Given this list of marker genes WBP2, ALDH3A2, MINDY2, SLCO3A1, AKT3 (AKT serine/threonine kinase 3), KDM5B, SYNPO, PTPRE, RIPK3, NIBAN1, DPY19L3, KMT5B, TAX1BP1, UVRAG, SUPT20H (SPT20 homolog, SAGA complex component), MOB1A, CMC1 (NCBI Gene Id 152100), PHF21A, GNPDA2, ZXDC, PDZD4, VRK3 (VRK serine/threonine kinase 3), PRKACB, DDIT4, PPP2R5E, TBRG1, MADD, CCDC18, DYNLRB1 (dynein light chain roadblock-type 1), CWC15, HMG20A, SERINC1 (serine incorporator 1), SIDT2, PTGER2, SMAP2, BPTF, BMAL1, BTD, SYNRG, RNF138, ERLEC1, PTPN11 (protein tyrosine phosphatase non-receptor type 11), TNIK, INSIG2, TSPAN13, SORL1, GOLM1, DOP1B, FAM120B, FBXO4, VPS41, SQSTM1, CHD8, HEXB, DDT (D-dopachrome tautomerase), B2M, MBNL1, RNF103, XRN2, NEMP2, ERMP1, ICE1, VPS26B, PML, NCF4, XPR1, HMBOX1, EEIG1, EPHX1, TMEM62 (NCBI Gene Id 95722), NMB, CDC42 (cell division cycle 42), RIMOC1, SMG1, FCHSD2, SERTAD3, TMEM167B, LEMD3, CYB5R4 (NCBI Gene Id 51167), FBXO25, NSMCE2, MDP1, SLC12A7, PARP3, XIST, RFX3, GIT2, EZH1, LDLRAP1, SPACA1, SCAPER, ZBTB20, MARCHF7, HACE1, PDE3B, CHD9, USP28, UBASH3B, HELZ, USP8, PLEKHA1, BTLA, PRKCH, TTF1, ZBTB1, SAMD3, C19orf38, RAPGEF6, FBXL3, DMXL1, CYTH1, PHYH, RGP1, MBNL2, EIF3H, EXOC2, ZCCHC7, LIMK2, ANKRA2, PDCD6IP, UBR2, KRCC1, TRIM59, GIMAP5, HTATIP2, P2RX7, HDAC8 (NCBI Gene Id 7492), CFLAR, PJA2, ERGIC3, ALDOC, ATP6V1G3, ZFAND3, RNF125, GPR174, PAPSS1, GRK6, SLC35B3, HEXA, NCAPD2, CIR1, TBC1D8B, SCML4, USP25, CEP97, PARP12, PHIP, SLC35D2, ZFC3H1, PDLIM5, IFT140, KDM5A, VAMP2, AP3S1, TLN1, CHMP1B (charged multivesicular body protein 1B), ZDHHC20, BRWD3, SCARB2, LEF1, MFSD1, MYL11, CRYZL1, CLINT1, PARP11, UBXN7, NAT2, here is a description of the gene set: from publication Gratchev A, Kzhyshkowska J, Kannookadan S, Ochsenreiter M, Popova A, Yu X, Mamidi S, Stonehouse-Usselmann E, Muller-Molinet I, Gooi L, Goerdt S (PMID 18453574) Genes up-regulated in macrophages differentiated in the presence of IL4 for 5 days versus those subsequently treated with TGFB1 for 24h. The goal of the study was to identify the effects of TGF-beta on primary human macrophages maturated under different conditions. Human Gene Set: GSE7568_IL4_VS_IL4_AND_TGFB_TREATED_MACROPHAGE_24H_UP species: Homo sapiens